The following is a description of a gene set: Cluster 6: genes down-regulated in SW260 cells (colon cancer) by sodium butyrate and sulindac. The short-chain fatty acid butyrate, produced by microbial fermentation of dietary fiber in the large intestine, is a physiological regulator of major pathways of colonic epithelial cell maturation: cell cycle arrest, lineage-specific differentiation, and apoptosis. Microarray analysis of 8,063 sequences demonstrated a complex cascade of reprogramming of SW620 colonic epithelial cells upon treatment with butyrate characterized by the progressive recruitment of gene sets as a function of time. Comparison with the effects of trichostatin A, in conjunction with differences in the kinetics of alteration of histone acetylation induced by butyrate and trichostatin A, identified subsets of induced and repressed genes likely coordinately regulated by altered histone acetylation. The butyrate response was also compared in detail with that of sulindac, a nonsteroidal anti-inflammatory drug with significant chemopreventive activity for colon cancer, and curcumin, a component of mustard and curry structurally and functionally related to sulindac that also has chemopreventive activity. Although gene clusters were identified that showed similar responses to butyrate and sulindac, the data were characterized by the extensive differences in the effects of the two agents. This was striking for functional classes of genes involved in signaling pathways and in cell cycle progression, although butyrate and sulindac induce a similar G0-G1 arrest, elevation of beta-catenin-Tcf signaling, and apoptotic cascade. As regards cell cycle arrest, the underlying mechanism in response to butyrate was most similar to that of the Caco-2 cell line that had spontaneously undergone a G0-G1 arrest and least similar to the G2-M arrest stimulated by curcumin. Thus, high-throughput microarray analysis of gene expression profiles can be used to characterize and distinguish the mechanisms of response of colonic epithelial cells to physiological and pharmacological inducers of cell maturation. This has important implications for characterization of chemopreventive agents and recognition of potential toxicity and synergies. The data bases, gene clusters, and analyses are available at http:// sequence.aecom.yu.edu/genome/. from publication Mariadason JM, Corner GA, Augenlicht LH (PMID 10969808) species: Homo sapiens Human Gene Set: MARIADASON_RESPONSE_TO_BUTYRATE_SULINDAC_6, and this is the list of marker genes: CDK6, HNRNPH1, NSD2, DHX9, ANP32A, GRIN1, SLC45A1, MLXIP, EIF4A1, TIA1, ST18 (ST18 C2H2C-type zinc finger transcription factor), TUBB4B, MDGA1, NCBP3, ITPR2, MAZ, SCAF11, TOP2B, CDK5RAP2 (CDK5 regulatory subunit associated protein 2), SORBS2, MGME1, MSI2, ZNF529, SMC2, CHDH, STAT2, IFITM2, RPRD2, SESTD1, DANCR, KHDRBS1, CTDSP1, NAP1L1 (nucleosome assembly protein 1 like 1), RFX7, RNF180 (ring finger protein 180), INPPL1, ATP5F1B, MAPK4, PCNA, MBNL3, MYB, HMGB2, TMPO, KMT5B, PLCB2, ETS2, ARID1B